The following is a description of a gene set: Human Gene Set: HP_ABNORMAL_SCLERA_MORPHOLOGY species: Homo sapiens Abnormal sclera morphology An abnormality of the sclera., and this is the list of marker genes: WASF1, ENPP1, CLCNKB, MED27, KDM1A, IPO8, PGM1, COL5A1, SERPINH1, WNT5A, IKBKG, PSMB8, CTCF, IFITM5, BMP1, TGFB3, CA2, PAX2, CANT1, PAX1, GATA1, TMEM163, CHSY1, MVK, SEC24D, RPS23, ADAMTS2, KRAS, SF3B2, UNC45A, POLR3A, PUS3, DVL3, DSE, CTSK, HLA-DPB1, COL1A1 (collagen type I alpha 1 chain), RMRP, ZNF469, TRMT5, PTPN22, DPAGT1, MC1R, KDM6A, ESCO2, NLRP3, NFIX, GDF11, TRMT10A, WNT1, GNB2, BCL11A, TGFBR2, COL12A1, DACT1, PRTN3, TENT5A, CYB5A, SALL1, OCA2, ABCC6, MSX2, RYR3, TELO2 (telomere maintenance 2), AKT1, ARL2, GHR, PPP1R15B, TGFB2, PLCB4, COL3A1, FKBP14, HLA-DPA1, HECTD4, EXOSC1, FBN1, PPP1R21, DVL1, KMT2A, HGD, MEGF8, CREB3L1, PHLDB1, PRMT7, PPIB, CHST3, CTLA4, ATP6V0A2, PIGT (phosphatidylinositol glycan anchor biosynthesis class T), WWOX, ROR2, TGFBR1, PTEN, KIFBP, PRKAR1A, IMPG2, XYLT1, INPPL1, VPS4A, MFRP (NCBI Gene Id 83552), SMAD2, COL1A2 (collagen type I alpha 2 chain), CHST14, PRSS56, PRDM5, MESD, BEST1, IDS, CSGALNACT1, C1R, B4GALT7, MBTPS2, DNASE1L3, B3GALT6, SP7, CYB5R3, SLC29A3, FGFR1, PRKG2, UROD, XYLT2, IGF2, CRTAP, POLRMT, CFAP410, FZD2, RNU4-2, KMT2D, FKBP10, COG4, B3GAT3, HADHA, P4HB, SERPINF1, SLC26A2, UROS, PYCR1, LRP5, NXN, SLC39A13, SMAD3, MAP3K7, SON, ALPL, PLOD1, TMEM38B